Given this list of marker genes Arhgap27, Arhgap44, Arhgap39, Gna13 (NCBI Gene Id 14674), Syde1, Myo9b, Def6, Arhgap24 (Rho GTPase activating protein 24), Pik3r1, Arhgef12 (Rho guanine nucleotide exchange factor 12), Arhgap32, Arhgap20, Cdc42, Itsn1, Mcf2l, Arhgap40, Ralbp1, Dlc1, Arhgef5, Arhgap33, Plekhg1, Srgap3, Dock9, Arhgap21, Racgap1, Arap3, Vav3, Arhgef6, Prex2, Arhgap5 (Rho GTPase activating protein 5), Fam13b, Fgd2, Arhgap1, Fgd1, Spata13, Arhgap22, Dnmbp, Ykt6, Abr, Arap1 (NCBI Gene Id 69710), Arhgef26, Farp1, Srgap1, Arhgap35, Cav1, Stard13, Arhgap30, Arhgap17, Dock8, Arhgef16, Rasgrf2, Mcf2, Plekhg3, Arap2, Prex1, Fgd4, Arhgap45, Arhgef9, Arhgap42, Dock11, Stard8, Dock6, Srgap2, Gmip, Ktn1, Arhgef10, Fgd3, Dock7, Dock10, Arhgap26, Arhgef25, Trio, Plekhg2, Arhgdib, Ect2, Vav2, Arhgef19, Ophn1, Tagap, Ngef, Arhgap29, Arhgap4, Arhgdig, Arhgap9, Arhgef15, Lbr, Depdc1b, Arhgap10, Arhgap31, Chn1, Bcr, Pik3r2, Arhgef11, Arhgdia, here is a description of the gene set: CDC42 GTPase cycle studied in species Mus musculus Mouse Gene Set: REACTOME_CDC42_GTPASE_CYCLE